The following is a description of a gene set: studied in species Homo sapiens The process that mediates interactions between an AV node cell and its surroundings that contributes to the process of the AV node cell communicating with a bundle of His cell in cardiac conduction. Encompasses interactions such as signaling or attachment between one cell and another cell, between a cell and an extracellular matrix, or between a cell and any other aspect of its environment. Human Gene Set: GOBP_AV_NODE_CELL_TO_BUNDLE_OF_HIS_CELL_COMMUNICATION, and this is the list of marker genes: GJC1, CACNA1G, GJA5, SCN5A, SCN10A, CACNA1C, SCN4B, GJD3, CACNB2, GJC3, TRPM4, RYR2, CXADR, MIR208A